The following is a description of a gene set: species: Homo sapiens Abnormal circulating T4 concentration Human Gene Set: HP_ABNORMAL_CIRCULATING_T4_CONCENTRATION A deviation from the normal concentration of thyroxine in the blood. Thyroxine (also known as T4) is the main hormone secreted by the thyroid gland into the blood. It can be converted into the active form triiodothyronine (also known as T3)., and this is the list of marker genes: SNRPN, SECISBP2, IYD, TPO, THRB, PAX8, PROP1, TSHB, LHX4, HESX1, ALMS1, DUOX2, MAGEL2 (MAGE family member L2), TG, NDN, TSHR, GLIS3, FOXE1, ALG8, TRHR, OCA2, POU1F1, DUOXA2, SLC5A5, LHX3, KCNJ18